The following is a description of a gene set: Hedgehog signaling pathway, PTCH coreceptor. Pathway ID: N01538. Pathway type: Reference. Pathway class: nt06501 HH signaling. species: Homo sapiens Human Gene Set: KEGG_MEDICUS_REFERENCE_HEDGEHOG_SIGNALING_PATHWAY_PTCH_CORECEPTOR Pathway Definition from KEGG: ((CDON,BOC),GAS1,LRP2) -> (HH+PTCH), and this is the list of marker genes: CDON, SHH, PTCH2, LRP2, BOC, PTCH1, GAS1, IHH, DHH